The following is a description of a gene set: studied in species Mus musculus from publication Schaeffer EM, Marchionni L, Huang Z, Simons B, Blackman A, Yu W, Parmigiani G, Berman DM (PMID 18794802) Mouse Gene Set: SCHAEFFER_PROSTATE_DEVELOPMENT_AND_CANCER_BOX4_UP Cancer cells differentiate along specific lineages that largely determine their clinical and biologic behavior. Distinct cancer phenotypes from different cells and organs likely result from unique gene expression repertoires established in the embryo and maintained after malignant transformation. We used comprehensive gene expression analysis to examine this concept in the prostate, an organ with a tractable developmental program and a high propensity for cancer. We focused on gene expression in the murine prostate rudiment at three time points during the first 48 h of exposure to androgen, which initiates proliferation and invasion of prostate epithelial buds into surrounding urogenital sinus mesenchyme. Here, we show that androgen exposure regulates genes previously implicated in prostate carcinogenesis comprising pathways for the phosphatase and tensin homolog (PTEN), fibroblast growth factor (FGF)/mitogen-activated protein kinase (MAPK), and Wnt signaling along with cellular programs regulating such 'hallmarks' of cancer as angiogenesis, apoptosis, migration and proliferation. We found statistically significant evidence for novel androgen-induced gene regulation events that establish and/or maintain prostate cell fate. These include modulation of gene expression through microRNAs, expression of specific transcription factors, and regulation of their predicted targets. By querying public gene expression databases from other tissues, we found that rather than generally characterizing androgen exposure or epithelial budding, the early prostate development program more closely resembles the program for human prostate cancer. Most importantly, early androgen-regulated genes and functional themes associated with prostate development were highly enriched in contrasts between increasingly lethal forms of prostate cancer, confirming a 'reactivation' of embryonic pathways for proliferation and invasion in prostate cancer progression. Among the genes with the most significant links to the development and cancer, we highlight coordinate induction of the transcription factor Sox9 and suppression of the proapoptotic phospholipid-binding protein Annexin A1 that link early prostate development to early prostate carcinogenesis. These results credential early prostate development as a reliable and valid model system for the investigation of genes and pathways that drive prostate cancer. Early prostate development genes (up-regulated at 6 hr dihydrotestosterone) which are also up-regulated in localized vs metastatic prostate cancers., and this is the list of marker genes: Irf2bp2, Nav1, Sin3b, Zmynd8, Prkcb, Cavin2, Fabp4, Ncoa6 (NCBI Gene Id 56406), Wac, Krt19, Klhdc10